Given this list of marker genes ZBTB8OS, RTRAF, TRPT1, RTCB, TSEN15, TSEN2, CLP1, TSEN54, C2orf49, DDX1, ERN1, FAM98A, TSEN34, FAM98B, here is a description of the gene set: Human Gene Set: GOBP_RNA_SPLICING_VIA_ENDONUCLEOLYTIC_CLEAVAGE_AND_LIGATION species: Homo sapiens Splicing of RNA via recognition of the folded RNA structure that brings the 5' and 3' splice sites into proximity and cleavage of the RNA at both the 3' and 5' splice sites by an endonucleolytic mechanism, followed by ligation of the exons.